Given this list of marker genes TNFRSF1A, ARX, MYPN, NEB, KAT6A, GABRA3, SPAST, PSAP, SLC2A1, IFIH1, SCN4A, DARS2, KCNA1, ACADVL, SAMHD1, TK2, GPHN, MYOT, AOPEP, HSPG2, KPNA3, CNBP, PHKA1, PYGM, CACNA1S, RNASEH2A, KLHL41, CPT2, PANK2, STIM1, ABCD1, PODXL, CAV3, VAMP1, ATP13A2, KRAS, TPM2, PRKAR1B, ZFYVE26, ATP2A1, RYR1, FGFR1, KIF1A, MT-ATP6, MAPT, SYNJ1, TREX1, PI4KA, LDHA, GLRB, MYO5A, KCNJ18 (potassium inwardly rectifying channel subfamily J member 18), TPM3, SLC6A5, SPG7, RNASEH2C, RNASEH2B, RNU7-1, LDB3, REEP2, CLCN1, KIF5A, PFKM, CAVIN1, ANO10, GALC, CRYAB, DNAJC6, ADAR, DHCR24, ANO5, SIL1, RNU4ATAC, ACTA1, SLC16A1, ATAD1, KIF11, KBTBD13, POLG, HINT1, DYSF, GLRA1, LSM11, MLIP, here is a description of the gene set: Human Gene Set: HP_MUSCLE_STIFFNESS A condition in which muscles cannot be moved quickly without accompanying pain or spasm. species: Homo sapiens Muscle stiffness